Given this list of marker genes GRAP, CABP4, OR2T35, GPX1, GRIN2D, OR1I1, OR5AK3P, GUCY2D, TBL1X, OR6C76, PDYN, OR8U3, SCNN1G, OR10G3, OR10Z1, OR52A5, LOXHD1, RD3, GSDME, OR2W1, FBXO11 (F-box protein 11), MGLL, OR51B6, OR13C7, OR12D1 (olfactory receptor family 12 subfamily D member 1 (gene/pseudogene)), OR2A25, OR52M1, GNAT3, OR2W6P, MIR762, MME, OR14C36, OR2L2, CCN3, OR13C9, OR2V1, COL6A1, COL18A1, KIAA0319, OR11H6, PAX6, OR6B2 (olfactory receptor family 6 subfamily B member 2), PCDH15, SCN10A, OR1E2, BACE1, OR6C70, CLN8, UBR3, DDIT3, VSX2, RDH10, OR4A4P, OR10D4P, RP2, NLGN2 (NCBI Gene Id 57555), OR13C8, RABGGTA, REST, TAS2R19, OR7A2P, LRAT, TUB, KCNA2, OR4E2, TAS2R10, CLDN19, OR6C2, ROR1, OR4K1, GPR179, TMTC4, OR4F4, OR1B1, TPRN, CALHM3, OR2Y1, KCNQ4, ZIC2, VSX1, OR10S1, ATF6, OR10A2, RDH11, OR4Q2 (NCBI Gene Id 81121), OR2A1, OR13C5, CEACAM16, ATP2B2, OR5AN1, PJVK (NCBI Gene Id 494513), TIMP3, OR2K2, OR10G2, ROM1, OR4A5, OR51B5, OR2T34, ABCC6, OR2M2, TACSTD2, OR9G9, OR6V1, TIMM8B, TAS2R46, HOMER2, RPGR, B2M, OR56A1, VN1R4, ATXN7, OR8K1, GJB4, OR2M7, OR7A17, ATP8B1, MAPK3, TAS2R41, OR5D16, GRM6, CNGA4, GPR171, OR5D14, GABRR2, DISC1, OR4F16, PRPH2, OR4X2, BSND, USH1C, TAS2R42, OR10G6, MFRP, OAT, OR10H5, OR52J3, HPS1, SLC45A2, OR13C6P, OR56A3, SIX1, OR4F29, TRPM8, SERPINE2, OR5H6, PROK2, OR51G2, OR2B3, MYO6 (NCBI Gene Id 4646), OR6B1, OR1D4, CRYBB3, SPTBN4, OR12D2, CHRNA7, SIX6, OR1D2, TAS2R60, OR9K2 (olfactory receptor family 9 subfamily K member 2), DRD2, OR4N5, RPGRIP1, OR2B6, OR51B4, OR2I1P, OR11H2, OR2M5, BFSP2, MYC, TAS2R39, RORB, OR10T2, STRC, CDKN1B, TRPA1, HOXA1, OR1S1, TAAR3P, CLN6, OR2AK2, WDR47, OPA3, OR9A1P, OR56B4, SCRN3, LCN1, CRYBA1, OR2M3, FZD2, RAB3A, OR2AJ1 (olfactory receptor family 2 subfamily AJ member 1), OR8U8, OR8A1, OR5H8, OR5H2, MYO3B, OR5AC1, OR5H14, PKHD1L1, OTOR, RHO, OR51T1, CACNB2, TAS2R8, CASP3, OR6N2, CRYBB2, OR4X1, OR11A1, CNNM4, OR7A5, RGS9BP (NCBI Gene Id 388531), SLC38A8, OR1J4, TTC8, REEP2, TAS2R4, SPATA7, GRIN2A, PDE6G, MC1R, EPAS1, OR6C1, LXN, OPN1MW, RGS21, NMU, OR8U1, FXN, RIMS1, OR2T6, FAM161A, OR4K13 (NCBI Gene Id 81129), GRIK2, OPN1MW2, KCNK2, OR10K2, SCARB2, GRK7, OR2A2, OR8U9, OR4C6, OR10A4, FZD4, CDC14A, DNAJC19, BARHL1, SCN9A, OR8B12, PKD1L3, BIRC5, OR5AP2, WNT10B, OR2T11, COL11A1, SCNN1B, SOX14, OR52L1, OR8J1, OR2A5, OR2T4, CST2, AOC2, OR2J3, RTP3, OR8G3P, OR5C1, OR4A47, TMEM150C, LHFPL3, CCL2, CABP1, OR5B3, CRYBA4, KCNJ10, TAS1R1, HEXA, OR5AS1, OR13F1, OR6C6, OR2B8P, OR2A42, OR1F2P, TRPM1, CA6, OR5B2, OR10G7, SMR3B, OR51G1, TH, OR5D13, PAX3, OR5P2, OR52B2, OR6Y1, OR5L2, OR4Q3, CLRN1, OR2L5, CNGA1 (NCBI Gene Id 1259), RAX2, OR8B3, HEXB, EML2, EFEMP1, UGT2A1, TMC7, P2RX2, CNGA2, OR6C3, OR52A4P, OR6K3, IAPP, OR2AG2, OR2T10, RPE65, OR56A5, MYO7B, OR6K6, RDH12, OR4D1, NPR2, MMP24, CLIC5, PDZD7, OR51B2, GUCY2F, FFAR4, SOBP, CDK5, OR5T1, GLRA1, BBS1, PHF24, OR1S2, P2RX7, OR2J2, P2RX4, OR1L8, OBP2A, P2RX3, OR10W1, OR2J1, OR5BS1P, NHERF1, OR4S2, SPX, OR2A14, TIMM9, MYO3A, OR9Q2, OR2T27, ANO9, TMIE, OR8G5, B3GNT2, CDKN2D, SFRP5, OR4B1, TAFA4, OR2B2, ASIC1, WHRN, OR13H1, OR4N2, CABP2, OR10A6, PNOC, RP1, CST1, CRYAA, POU3F4, DLL4, CRYGA, BEST2, OR5AK2, OR1L1, OR9A4, CRYBG3, OR10K1, TAS2R30, OR10G4, OR7C2, OR2Z1 (olfactory receptor family 2 subfamily Z member 1), LARGE1, LHFPL4, OR4D2, OR52K1, OR2T8, TMC1, OR2H1, ATPSCKMT, TULP1, CRYZ, GNAT2, TRIOBP, SCNN1D, CRYBA2, OR3A1, OR2T29, OR4D9, OMP, OR5H1, EYA3, RCVRN, OR8J3, NOB1, AQP1, TAS2R5, PENK, BBS7, LRP2, VN1R1, POU4F3, OR1C1, OR4P4, KCNA1, COL1A1, LPO, OR2A12, ALDH7A1, HOXD1, CCR2, OR8D1, OR5B17, CEP250, OR9G1, OR4K14, GPR148, OR11H12, LAMB2, OR7A10, GJC3, LRIG1, OR1J2, CRX, PIRT, OR6C75, TAS2R1, OR11H4, RGS16, PIEZO2, TAS1R2, OR13D1, OR11H1, PPEF1, OR2AG1, PDE4A, PDC, POU6F2, OTOF, OPN4, OR8D4, OR8D2, OR10J1, OR4K2, TAS2R13, OR4C12, OR4C11, OR14I1, RLBP1, CHM, TAS2R40, OR3A3, ELMOD3, OR10J5, GRXCR1, OR2B11, OR9G4, REEP6, NMB, CHRNB2, LEF1, OR5AC2, GJB6, ITGA2, CPLX3, MIR342, GRM8, OR2L8, OR4C45, CEMIP, GIP, C5AR1, OR52W1, IMPG2, GNB1, OR5J2, OR8B2, PDE6C, TAS2R20, OR6C68, OR5K1, OR4D10, OR10C1, TBX1, WFS1, CNGB1, OR5M11, PGAP1, OR4F3, OR2A7, TAS2R9, AXIN1, FGFR1, OR2G2, OR14L1, OR51A2, OR1L4, TAS2R50, OBP2B, OR13A1, USP53, OR52E1, OTOA, RAX, OR2M4, ATP6V0A4, OR51F2, CCL3, GRK1, OR5D18, OR4A15, OR11H7, OR51F1, PDE6B, KCNK4, CDH23 (NCBI Gene Id 7395), MYO1A, OR10H4, OR52E4, SLC1A3, OR5P3, OR3A2, OR2D2, RPL38, NDUFB9, MYH14, OR51C1P, OR52N2, CRYGS, DIAPH1, CDH3, OR2F1, OR52E8, TULP2, OR2F2, EYS, OR2W5P, PDE6D, GBX1, OR5G3, OR5B21, OR1D5, OR7G2, OPRK1, UCN (NCBI Gene Id 7349), POMGNT1, OR52I1, OR2G3, OR13J1, OR5A1, POMK, POU4F1, OR2V2, TAS2R16, OR2AE1, OR6A2, UNC119, TMEM87A, OR51I1, ACP3, SPRY2, OR4D11, PPEF2, OR8H2, EPS8L2, ALOXE3, OR2S2, OR5M9, OR56A4, GUCA1ANB-GUCA1A, MRGPRX2, MINAR2, CRYGD, OR51A4, IMPG1, OR4K17, OR10H2, HOXB8, PTGES, PIP, SLC6A3, ANO1, OR4C46, CD36, DCDC2, ABCA4, GUCA1C, TECTA, CACNB4, OR6S1, ARL6, OR4N4, OR7G3, NGF, BTBD9, EPYC, TAS2R3, OR52L2P, CNGB3, MYO7A, RIC8B, NR2F6, NXNL2, ITPR3, ADORA1, THRB, RBP4, OR51J1, TRPV1, RTP1, OR9A2, OR52N4 (olfactory receptor family 52 subfamily N member 4), OPRM1, ZNF513, TAAR6, ARR3, OR5T2, BEST1, COL4A3, TAAR5, OR2T5, OR5V1, EPHB1, OR51L1, OR4M2, OR52E5, SLC24A1, OR1J1, GUCA1A, CRYGN, PITPNA, OR1A1, TGFBI, OR7G1, OR4L1, OR1P1, VN1R2, TRPV2, OR11G2, ZNF354A, OR52P1, OR2C1, OR2C3, HTR2A, ATP6V1B1, OR10D3, USH1G, OR2L3, OR1M1, MYO15A, OR5M8, OR4F21, RTP4, OR13C4, OR2T2, OR4C3, OR10AC1, OR52N1, OPN1LW, LRIT1, OR4F17, OR6B3, RP1L1, PCARE, OR56B1, SMR3A (NCBI Gene Id 441021), SCN11A, GJA3, GNAS, CNTN5, OR4E1, OR4A8, VN1R3, CACNA1D, OR2H2, OR8B4, OR52E2, OR2W3, PIGR, OR5B12, OR6F1, TMC2, OR14A16 (olfactory receptor family 14 subfamily A member 16), CHRNA10, ESPNL, PLCB2, CNGA3, OR4M1, ZFHX2, OR6M1, CFAP69, HMCN1 (hemicentin 1), TNF, OR10G9, TIMM13, SHANK1, CHD7, SLC26A4, PRDM12 (NCBI Gene Id 59335), RIPOR2, OR10A3, CRB2, CLN5, PKD2L1, OR1E1 (NCBI Gene Id 8387), RABGGTB, OR10V1, LHFPL5, GNAT1, OR10AG1, OR9I1, SLC24A4, SPNS2, COMT, OR51A7, NDP, STX4, GRM7, OR13C2, OR4S1, OR5AU1, OR7D4, OR5W2, CLRN3, OR12D3, CYP4V2, OR4F6, COCH, CRYGB, OR6X1, RETREG1 (reticulophagy regulator 1), OR6C74, BBS4, OR4F15, COL2A1, OR10G8, TAC1, NTSR1, OR51H1, SLC26A5, CXCL12, TMPRSS3, TAC4, HPN, OR6P1, BBS9, SCNN1A, CRYM, OR1L6, OR52B6, OR7E24, OR5AR1, TMEM120A, GRM1, OR1F12P, MIP, RBP3, ESPN, NYX, OR14J1, NPY1R, TAS2R31, OR8H3, ANKFN1, OR5M1, SLC4A10, TAS2R14, OR5K4, CLRN2 (NCBI Gene Id 651058), GPR143, OR6Q1, ADCY3, OR6J1, OR52E6 (olfactory receptor family 52 subfamily E member 6), OR13G1, FSCN2, OR52N5, OR51Q1, TAS2R38, TYR, OR5F1, CHRNA4, OR8J2, KCNK9, SRRM4, CRYBB1, OR10AD1, OR2T33, RRH, OR10H1, FABP5, KIT, NDN, RDH5, OR2G6, OR8I2, CPLX4, NR2E1, BBS10, RGR, OR1G1, MECP2, DIAPH3, OR10H3, ADORA2A, OR51S1, ABCB1, LRIG2, TAAR9, OR11L1, COL11A2, SCN1A, TAS2R7, OR51I2 (NCBI Gene Id 81279), TIMM10, RTP2, RS1, TFAP2A, KRT12, RTP5, OR13C3, OR2D3 (olfactory receptor family 2 subfamily D member 3), SOD1, OR6K2, KIFC3, SNAI2, OR5AL1, OR2L13, OPN1SW, PRR4, SEMA5B, OR5M10, GJC1, OR4A16, OR1N1, DRGX, LUM, OR8H1, GLRB, PDCL, NAV2, USH2A, OR4M2B, OR5I1, MKKS, SLITRK6, TAS2R45, TAS2R43, OR51M1, OTOS, CCDC50, OR8S1, OR2T12 (olfactory receptor family 2 subfamily T member 12), OPN5, OR2T3, GUCA1B, NIPSNAP1, KCND2, GFY, GJD2, LCTL, SLC52A3, OR1Q1, OR51D1, OR5A2, PAX2, OR52A1, OR14K1, OR4K3, OR1K1, OR4C16, OTOGL, TMEM100, CACNA2D4, WDR1, CRB1, OR52I2, POU4F2, OR8G2P, GJA10 (NCBI Gene Id 84694), VN1R17P (NCBI Gene Id 441931), ASIC3, PTPRQ, PDE6A, OR4C13, OR14A2, OPA1, OR10J6P, KERA, OR6C65, GNAL, WDR36, OR51E1, OR2T1, OR1E3, OR7C1, OR52D1, NIPBL, LAMC3, OR10Q1, FYN, OR2A4, DRAM2, OR1A2, AZGP1, RGS9, OR1F1, GNG13 (NCBI Gene Id 51764), EYA4, LRIT3, ANKRD24, OR6C4, OR52K2, CCDC66, OR5K2, DHRS3, AIPL1, OR9Q1, ADRA2A, PDE6H, PRCD, OR2T7, OR6N1, OR2AT4, ADGRV1, OR8B8, OPRPN, MIR324, NTRK1, OR5K3, OR1L3, KCNQ1, OR5L1, IRX5 (iroquois homeobox 5), OR52H1, NTSR2 (NCBI Gene Id 23620), NRL, RDH8, OPN1MW3, OR4F5, CST4, MBP, NR2E3, KCNQ3, OR4D5, OR4K5, PPIP5K2, GET1, TSPEAR, OR52Z1P, OPRL1, ATP8A2, MYO9A, TAS1R3, SLC17A8, OR4K15, VAX2, OR10X1, OR8K5, BBS5, OR7D2, CRYGC, OR51E2, OR5H15 (NCBI Gene Id 403274), MARVELD2, OR8G1, KCNE1, OR4D6, OR10J3, OR10P1 (NCBI Gene Id 81150), CALHM1, OR10R2, GJB2, ABLIM1, OR6T1, OR52R1, OR10J4, OR5M3, SERPINB6, OR51V1, SIX3, OR1N2, CHRNA9, CACNA1F, OR4C15, OR2AP1, GRXCR2, OR56B2P, BBS2, OR52B4, OR4C5, ELFN1, ASIC2, MIR455 (NCBI Gene Id 619556), OR8K3, TMEM63B, OR5T3, PPT1, OR10A5, OR10A7, SYT10, EYA1, here is a description of the gene set: studied in species Homo sapiens The series of events required for an organism to receive a sensory stimulus, convert it to a molecular signal, and recognize and characterize the signal. This is a neurological process. Human Gene Set: GOBP_SENSORY_PERCEPTION